The following is a description of a gene set: Genes predicted to be targets of miRBase v22 microRNA mmu_let_7c_1_3p in miRDB v6.0 with MirTarget v4 prediction scores > 80 (high confidence targets). from publication Chen Y, Wang X (PMID 31504780) Mouse Gene Set: LET_7C_1_3P studied in species Mus musculus, and this is the list of marker genes: Gdf6, Rims2, Smarcc1, Arhgap44, Zbtb43, Cul3, Ndn, Arfgef1, Taok1, Eif4b, Sox8, Rasl11b, Derl1, Mideas, Sox2 (SRY (sex determining region Y)-box 2), Bcl11a (BCL11 transcription factor A), Dab1, Gphn, Ascl1, Trrap, Tor2a, M6pr, Rbbp5, Cdyl, Tbc1d22b, Otud4, Zfp148, E2f4, Eomes, Phf2, Dnaja2, Elavl1, Pot1a, Dscaml1, B4galt6, Sinhcaf, Cdh11, Slc30a7, Phtf2, Mbnl1, Pcdh7, Faxc, Adam19, Pias3, Mrtfb, Rgs3, Sox3, Mospd2, Psmc6, Alx1, Rictor, Acer3, Trp63, Akirin1, Tlk1, Dkk1 (NCBI Gene Id 13380), Grb10, Fbxl3 (F-box and leucine-rich repeat protein 3), Kat6a, Pes1, Rab11fip3, U2surp (NCBI Gene Id 67958), Rab40c, Dennd4c, Susd6, Slitrk6, Adcy6 (adenylate cyclase 6), Onecut2, Mier3, Yy2, Sema3e, Strbp, Lzts2, Taf4, AW551984 (expressed sequence AW551984), Tbc1d12, Snx25, Npat, Met, Cnrip1, Tsc22d2, Axin1 (NCBI Gene Id 12005), Ppp1r8, Fgf18, Klf4, Cdh8, En2, Mbnl2, Uri1, Rnft1, Skil, Otud1, Slc25a12, Rarb, Mnt, Sorbs2, Mapk9, Nampt, Ep300, Myg1, Pkn2, Cited2, Tmprss11g, Gtpbp2, Zfp638, Vash2, Frmd6, Slit2, Morf4l1, Rev3l, Kdm2b, Ttll5, Nr4a3, Gabpb1 (NCBI Gene Id 14391), St8sia4, Ubqln2, Rbm27, Azi2, Klhl8, Megf11, Efr3a, Snrpb2, Pisd, Srebf1, Nudt21, Cldn23, Pofut2, Nr2e1, Tmem201, Yipf6, Cacna2d2, Bcl7a, Samd8, Usp38, Stk39, Tcf7l2, Calm2, Npy5r (neuropeptide Y receptor Y5), Rab39, Btbd7, Golga1, Snrpd1, Nipbl, Fmnl3, Six1, Zfp703, Rimbp2, Ppp1r10, Gls, Csmd2 (CUB and Sushi multiple domains 2), Atp5mk, Tacc1, Adamtsl1, Gtf2ird1, Socs4, Arid4a, Cdkn1c, Fubp1, Slain2, Cavin4, Elfn1, Pls3, Fam76b, Prr12, Mllt10, Memo1, Nap1l4, Ankrd12, B3galt1, Ccna2, Stat5a, Ulk1, Rbbp6, Mex3d, Scamp5, Asxl1, Stx16, Coq2, Grid1, Stag1, Arid4b, Gna13 (NCBI Gene Id 14674), Gli2, Rxra, Sox11, Nxph2, Adnp, Wac, Ube2f, Lrig1, Mfap3l, Eif4enif1, Cherp, Cep170, Slc6a6, Rreb1, Or4d10c (NCBI Gene Id 258805), Cd9, Hmgn1, C2cd4b, Mbtd1, Eif1ad3, Gria3, Nsd3, Hspd1, Zfp229, Tnc, Fmn1, Mrgprg, Khdrbs1, Sat1, Plaa, Map3k2, Shox2, Atp13a3, Sertad4, Nedd4l, Rapgef2, Ankrd26, Clca3a1, Dach1, Smg1, Selenop, Stard13, Kmt2e, Evi2a, Jarid2 (NCBI Gene Id 97879), Osbpl8, Pdia3, Ebf2, Nktr, Kcnc2, Sox15, Zic2, Ppat, Sec24d, Cul4a, Ube2g1, Sox9 (NCBI Gene Id 70015), Mpdu1, Zfhx3, Btaf1, Lrp6, Scaf8, Zeb2, Syt4, Csmd1, Hecw2, Ypel2 (NCBI Gene Id 77864), Rspo3, Hnrnpu, Dmd, Samd4, Fermt2, Mef2c, Ccdc6, Lmtk2, Pum1, Jade2, Sirt1, Sufu, Sipa1l2, Irf6, Apc, Cdk17, Jazf1, Grip1, Zfand5, Mt2, Rad21, Npas2, Top2b, Shisa3, Dnm1l, Sec11a, Stxbp5l, Nptxr, Foxo1, Ppargc1a, Smpx, Akap1, Zfr, Tal1, Rprd1a, Bmi1, Scrib, Ppp2r5c, Enkd1, Leo1, Ppp3r1, Hmgcr, Tab3, Kif26a, Orc4, Rab10, Nlk, Dyrk4, Npcd, Eif1ad7, Trim2, Setbp1, Plppr1, Elovl5, Elmod2, Ptprc, Krit1, Wnt5b, Zdhhc20, Cyrib, Pald1, Clk4, Kmt5b, Klhl5, St7, Herc1, Actr6, Celf5, Cacna1d, Zfp654, Znrf3, Kras, Gpm6a, Tdo2 (NCBI Gene Id 99471), Sp1, Evi5, Creb5, Gclc (glutamate-cysteine ligase, catalytic subunit), Kpna4, Trio, Gjc1, Fgf7, 1700028K03Rik, Foxf1, Tcerg1l, Eif1ad8, Tcte1, Kmt2c, Fzd1, Wdfy3, Fam43a, G3bp1, Cops7b, Sumo2, Ahctf1, Gbx2, Bcl6, Krt2, Xk, Adamtsl3, Slc33a1, Gabra5, Rgmb, Hoxb2, Carm1, Hivep2, Map4k3, Setd1a, Dpp4, Rnf38, Mbd5 (NCBI Gene Id 98951), Fbxl16, Nfkbia (nuclear factor of kappa light polypeptide gene enhancer in B cells inhibitor, alpha), Qki, Sp3, Rab35, Jmjd1c, Gca, Pum2, Gata2, Ift56, Nek7 (NCBI Gene Id 98561), Rin2, Ppp6r3, Sf3b3, Thoc2, Lig3, Angpt1, Lonrf1, Ctdspl2, AI593442, Fbxo21, Neo1, Klhl14, Nelfa, Gnas, Rab40b, Fam149b, Spry2, Myt1l, Rdx, Grin3a, Abcc5, Pan3, Nek6, Cdk13, Ints10, Rnps1, Rsl1d1, Phip (pleckstrin homology domain interacting protein), Lrrc4, Col13a1, Garre1 (granule associated Rac and RHOG effector 1), Pdia5, Dock4, Npas3, Prrc2c, Ranbp9, Runx2, Unc93a, Mtrex, Lrrtm3, Rgs7bp, Grhl2, Adam10 (a disintegrin and metallopeptidase domain 10), Septin7, E2f8, Tnfrsf11b, Fbln5, Scyl1, Nme7, Gdnf, Cdc42se2, Tmem45a2, Zbtb33, Brd10, R3hdm1 (NCBI Gene Id 226412), Rsl24d1, Rnf216, Col6a5